The following is a description of a gene set: studied in species Homo sapiens An abnormal sensation of spinning while the body is actually stationary. Human Gene Set: HP_VERTIGO Vertigo, and this is the list of marker genes: GCDH, TRDN, FLI1, TTN, EPOR, MYD88, SCN2B, IL12A-AS1 (IL12A antisense RNA 1), VSX1 (NCBI Gene Id 8198), SH2B3, CALM2, CASQ2, SLC1A3, KCNQ1, NOP56, STAT5B, FIP1L1, KCNA5, GLA, SDHB, KCNJ10, GATA6, MPL, STAT4, VHL, CNNM2, GATA2, TLR4, IL10, COCH, CCND1, SLC25A11, PTPN22, SCN3B, NF1, MDH2, CHD2, KCNJ2, SCN1B, JAK2, NUP155, NR0B1, GABRB3, PRKAR1A, CALR, KLRC4, HLA-DRB1, CACNA1G, NKX2-6, GCGR, IRF2BP2, IL12A, JUP, NUMA1, DBH, KCNE2, SCN5A, NPM1, CACNA1A, MAPK10, CUX2, THPO (NCBI Gene Id 84434), ADA2, AIFM1, MVK, SUFU, P4HA2, CTNNB1, SCN4B, GATA5, FAS, TPK1, LRP4, MYL4, HLA-B, MEN1, NAGA, ZBTB16, ABCC9, IL12B, MEFV, RYR1, TRPM4, MYO7A, CALM3, UBAC2, KIF1B, SDHC, CCR1, NPPA, TET2, SCN1A, KCNE1, KCNJ3 (NCBI Gene Id 3760), CLCNKB, RET, KCNQ2, COL3A1, GJA5, ATP1A2, SDHD, RARA, GYG1, BCOR (NCBI Gene Id 57686), ERAP1, NKX2-5, EPAS1, MAX (NCBI Gene Id 4149), TP53, PML, IFNGR1 (interferon gamma receptor 1), TECRL (trans-2,3-enoyl-CoA reductase like), STAT3, C4A, TBL1XR1, DNMT3A, DNM1 (NCBI Gene Id 1759), PRRT2, CALM1, RYR2, MED12, TNFRSF1A, DKK1, DLST, SLC26A4, KCNJ5, PITX2, CACNB4, SRPK3, AIP, MYL2, SCN2A, BRAF, FOXI1, TMEM127, NF2, SDHAF2, IL23R, PDGFB, SDHA, CDH23 (cadherin related 23), NABP1, GATA4, KCNA1, FGF14, FH, MLX (MAX dimerization protein MLX), SLC12A3